Given this list of marker genes Hsd17b1, Hsd17b2, Hsd17b6, Akr1c18, Srd5a2, Dhrs9 (dehydrogenase/reductase 9), Hsd17b8, Hsd17b3 (NCBI Gene Id 15487), Dhrs1, Akr1c20, Akr1c14, Hsd17b10, Akr1c6, Akr1cl (aldo-keto reductase family 1, member C-like), Hsd17b14, Hsd3b1, here is a description of the gene set: Catalysis of the reaction: testosterone + NAD(P)+ = androst-4-ene-3,17-dione + NAD(P)H + H+. Mouse Gene Set: GOMF_TESTOSTERONE_DEHYDROGENASE_NAD_P_PLUS_ACTIVITY studied in species Mus musculus